The following is a description of a gene set: part of: Drug ADME Reactome Pathway: Ciprofloxacin ADME electronically inferred by orthology from the curated human pathway studied in species Mus musculus This event has been computationally inferred from an event that has been demonstrated in another species.<p>The inference is based on the homology mapping from PANTHER. Briefly, reactions for which all involved PhysicalEntities (in input, output and catalyst) have a mapped orthologue/paralogue (for complexes at least 75% of components must have a mapping) are inferred to the other species., and this is the list of marker genes: Abcg2, Alb, Slco1a4, Slc22a1